Given this list of marker genes Vps72, Gfod1, Car14, Cnot8 (CCR4-NOT transcription complex, subunit 8), Atosb, Cacng2 (calcium channel, voltage-dependent, gamma subunit 2), Ap4m1, Mvk, Mttp, Oxsr1, Zfyve19, Tpm1, Nr6a1 (nuclear receptor subfamily 6, group A, member 1), Snip1, Btbd2, Mrtfa, Ikzf5, Hypk, Gm12002, Tcta, Tonsl, 1700122E12Rik, Inpp5e (inositol polyphosphate-5-phosphatase E), Sp3os (NCBI Gene Id 67686), Uckl1, Ap1g1, Plod3, Azin1, Mylk3, Hcfc1r1, Mrpl1, Rab40c, Zbtb7a, Hnrnpd, Fhod3, Habp4, Gm9955, Usp30, Plekha7, Mir2139, Fhod1, Pla2g5, Gins4, 6430573P05Rik (NCBI Gene Id 403193), Arl5b, Add3 (NCBI Gene Id 98171), Washc2, Cep152, 4933427E11Rik, Banp, Wdfy1, Sorbs2, Dnajc15, Haus8, Rcan2, Ndufa12, Prune2, Sharpin, Ctbp1, Smu1, Tacc3, Sec14l1, Baiap2l1, Prdx5, Cd36, Pcm1, Gm25630, B230369F24Rik, Spsb3, Ap3s2, Tmem120b, Ddx59, Gbe1, Aebp2, 1700086O06Rik, Dusp7, Ate1, Cox20, Uqcc1, 4933427D14Rik (NCBI Gene Id 97740), Gm4189, Mepce, Ciz1, Gstz1, Gm15612 (predicted gene 15612), Mob1b, Bloc1s1, Gm2287, Med31, Tcof1, Aldh16a1, Erh, Man1c1, Rnf31, Psmd12, Ndufb3, Rwdd1, Tnfrsf21, Zfp446, Lrrc3b, Cfap300, Polr1a, Pygo2, Kat14, Cep95, Smad3, Adal, Ttc9c, Ostm1, Gm9917, Ankrd16, Mir22, Trip12, Pgm2l1, Grk4, Samm50, Wdfy2 (WD repeat and FYVE domain containing 2), Tns3, Mrps25, Ifrd1, Prn, Tgfbr3, Pip5k1c, Tpk1, Nat10, Slc35f6, Ggct, Nmrk2, Rbsn, Gga2, Uggt1, Nhlrc3, Uck1, Hjv, Fdxacb1, Slc25a19, Gm38250, Ap1m1, Slc66a3, Mlec, Gm15523, Etfb, Casc3, Zbtb40, 4921536K21Rik, Serac1, Mybpc3, Gdi2, Esyt2, Cul2, Dbi, Pum2, Tnni3, Arid1a, Prkra, Timm10, Trib2, Phlda1, Naa40 (NCBI Gene Id 70999), Odad4, Cep41, 9430038I01Rik, Atxn7l1, Ccnl1, Ptpdc1, Gm10778, Pvr, Rhoa, Gtf2h3, Dimt1, Nop14, C9orf72, Suco, Esrrb, Tial1, Mtln, Ndufa10, A130014A01Rik, 1700007L15Rik, Idi1, Rbm27, Psma1, Inf2, Atp6v0d1, Asap1, Srsf6, Mir1191b, Frmd6, Ndufa5, Wipf2, Six5, Dhrs7, Hmcn1, Mrpl43, Dedd, Ddx42 (DEAD box helicase 42), Appl2, Zfp62, Rae1, Asb15, Alg11, Foxo6os, Pbx1, Dpy30, Rbm20, Tmem94, Hectd2os, Atn1, Ntmt1, Nexn, Fry, Rnf139, Zfp106, Jak1, Tpst2, Rap1gap2, Amotl2, Top3b, Mtmr6, Gm16793, Aamdc, Rbis, Nup54, Capzb (capping actin protein of muscle Z-line subunit beta), Ube2d3, Tmem51os1, Klhdc7a, Arl14ep, Invs, Usp31, Clptm1l, Dleu2, Dnajc16, Mrps26, Zcwpw1, Pmp22, Nceh1 (NCBI Gene Id 320024), Arhgap23, Gm12860, Odad3 (outer dynein arm docking complex subunit 3), Mindy2, Elac2, Klf13, Btrc (NCBI Gene Id 12234), Etl4, Pdhb, Mtx1 (NCBI Gene Id 17827), 3300002A11Rik, Trmt112, Rmi1, Dgkz, Atox1, Slc39a9, Rsrc1, Napepld, Atp7b, Ephx2, Xpo1, Lrrc27, Hsp90ab1, Rnf44, Fam220a, Fkbp4, Cul9, Zfp142, Gm22357, Smpd3, Pphln1-ps1, Pdp1 (pyruvate dehydrogenase phosphatase catalytic subunit 1), Foxp4, Ttc13, Taok3, Gnao1, Myo6 (myosin VI), Mtfr1l, Rxylt1 (ribitol xylosyltransferase 1), Firrm, Cenpc1, Cdkl3 (NCBI Gene Id 213084), Kmt2a, Ppp1r13b, Svil, C630043F03Rik, Mars1, Tead1, Bahcc1, Sertad2, Gmpr2, Tbc1d9b, Pank3, Mcee, Gstm1, Smyd1, A430035B10Rik, Ssbp2 (single-stranded DNA binding protein 2), Speg, Tcea1, Dusp18, Tent4b, 5430400D12Rik, Ankrd9, Grn, Mphosph10, Wars1, Kmt5a, Tnfaip8, Efhc1, Pabpc4, Raf1, Mir191, Mcfd2, Gucd1, Apobec2, Nup58, Phf1 (NCBI Gene Id 52012), Nedd8, Ift25, 4930583K01Rik, Lrrc10, Klhl12, Schip1, Ndufv3 (NCBI Gene Id 78330), Bltp2, Mbtd1, Plk3, Cbr2 (NCBI Gene Id 12409), Selenok, Arhgef19, Mir7238, Oplah, Tab1, Fyn, Gm9968, Hspb6, Setd1a (SET domain containing 1A), Zcchc2, Rptor, Ppm1h, Psmd13, Mir17hg, A730020M07Rik, Ezh2, Myom2, Znhit3, Ifngr1, Ubap2, Gm12092, P2rx4, Rtl5, Stard3, Pinlyp, Cipc, Popdc2, Ralgapb, Nuak1, Tsc1, Acrv1 (NCBI Gene Id 11451), Cab39l, Lyset, Shroom3, Tst, Tmem65, Ndufc2, Otof, Ears2, Erc1, Set, Ralgps2, Cep290, Dip2c (NCBI Gene Id 72929), Napa, Abcg2, Kcnk3, Nub1, Trmt10a, Prrg2, 6230400D17Rik, Hhatl, Nolc1, Orai1, Eml4, Mertk, Pdcl3, Unc50, Hycc2, Mrpl2, Adprhl1, Mir3091 (NCBI Gene Id 100526556), Cops4, Atg9a, Tmem171, Trim63, Wdr4, Cox8b, Phf19, Hnrnpk, Vhl, Gm26224, Polr1f, Chchd1, Prkag1, Ltbp4, Mm2pr, Gm23119, Zfp384, Lactb, Lmbrd1, Fzd2, Stat5a, Rrad, Fbxl19, Gm4419, Acacb, Arhgef12, Mybpc2, Mrpl47, Gpsm1, Idh1, Ddx49, Tnik, Rnf123, Fam131a, Thoc6, Kdm2a, Robo2, Ptbp1, 4930405A21Rik, Rsf1, Neo1 (NCBI Gene Id 78386), Polr3e, Psme2 (NCBI Gene Id 19188), 4833445I07Rik, Opn1sw, AW209491, Zfp975, Pik3cb, Fam136a, Vps13d, Hspb2, P4ha2, Eci1 (enoyl-Coenzyme A delta isomerase 1), Iffo1, Rpl13a, Prmt2, Hmgb1, Zfp113, Plcxd2, 4933440J02Rik (RIKEN cDNA 4933440J02 gene), Rbm38 (NCBI Gene Id 56190), F730043M19Rik, Fmc1, Pnrc1, Adck5, Prkar1b, Pcid2, Ube2g1, Edrf1, Stoml2, Ankrd50, Fam32a, Mrps36, Vdac2, Lmod2, Pdha1, Vac14, Uri1, Sar1a, Rdh5, Scube2, Clcc1, Ogdh, Nubp2, C630004L07Rik, Nkiras1, Zbtb37, Rcor2, Slc35e2, Nubpl (nucleotide binding protein-like), Mafa (MAF bZIP transcription factor A), Tmco3, Nol11, Ino80, Mir8098, Esco2, Ubr2, Cep85, Kdm4b, Htra2, Odr4, Fam53a, Mexis, Stc2, Slc39a14, Tlcd1, Klc4, Sirt3, Gm11511, Atp6ap1, Cfap68, Tmem170b, Exo5, Syne1, Noct, Tpr, Abhd11, Cdca3, Abtb1, Fn3krp, Afg1l, Mb, Pum3, Prdx3, Mob2, Lonp1, Rapgef2, Adora1, Mtx3, Cgrrf1, Pmm1, Ube2i, Ago1, Synpo, Strit1, Fbh1, Jade1, Rps21, Pet117, Pet100, N6amt1, Trap1, Tecrl, Rbm14, Smg1, Ppp3ca, Cul4a, Mcmbp, Mettl18 (methyltransferase like 18), Bach2, Acadsb, Tbl2, Lsm11, Txndc9, Itgb3bp, Parm1, Atp5mc3, Proser3, Abra, A730061H03Rik, Rassf1, Mgat4b, Ube2e2, Lcn5, Snord3a, Calr (NCBI Gene Id 12317), Coro6, P3h1 (prolyl 3-hydroxylase 1), Arv1, Etfa, Glcci1, Acaa2, Phactr4, Rangap1, Wdr19, Gm25794, Rab3gap1, BC005624, Txndc11, Mir7117, 6430571L13Rik, Tbc1d14, Gpn1, Qki, Ttc39b (NCBI Gene Id 69863), Fubp1, Prkag3, Pfkfb4, Irgq, Tomm6, Serinc1, Sardh, Ubfd1, Trmt10b, Txndc17, Samd1, Dner, Fbxw7, Emc2, Fxyd1, Rmc1, Tor1aip1, Zfp458, Cdk2ap1, Shld1, Tmem129, Nxn, Gas5 (growth arrest specific 5), Ahcyl2, Ccdc59, Ptcd1, Tbl1xr1, Bbs10, Hmg20a, Hspb7, Alpk2, Gm22394, Xab2, Paxx, Agpat3 (1-acylglycerol-3-phosphate O-acyltransferase 3), Hspb8, Ccdc47, Pex1, Orm3, Usp20, Ube2b, Hdac5, Tmtc3, Pcsk5, Mrpl49, Fbxo36, Utp18, Serbp1, 1810021B22Rik, Gata4, Adamts3, Mef2c, Lipt1, Gatd1, Limch1 (NCBI Gene Id 77569), Lgr6, Apbb1, Prkca, Erp44, Nectin2, Zfp777, Dhx36, Gemin6-ps, Gm9903, Irx3, Tnnt2, Bbof1, Maf1, Rfx1, Oxnad1, Slc25a39, Dusp1, Osbpl8, Phka1, Elmod3, Dhcr7, Mad1l1, Fitm2, Fbxo46 (NCBI Gene Id 243867), Bod1l, Pjvk, Alkbh5, Trp53rkb, Gm22489, Ccdc150, Mesd, Igfbp4, Hs6st1 (NCBI Gene Id 50785), Atg2a, Eapp, Chd3, Pdlim5, Gm15270, Katnip, Snd1, Prdm4, Api5, Pih1d1, Txn1 (NCBI Gene Id 22166), Ciao2b, Gfus, Gm14488, 6030469F06Rik, Sned1, Myom3, Hdgf, Katnb1, Ankrd10, Retsat, Lamc1, Dolk (dolichol kinase), Dnajc11, BB218582, Ccdc85c, Ints4, Rex1bd, Wdr25, Ndufaf3, Atp5mf (ATP synthase membrane subunit f), Cul5, Klhl26, Cbr4, Tmem266, Cpsf4, Clp1, Ggps1, Ptgs1, Aup1, Slc50a1, Rnf13, Klf4, Ppp2r5a (protein phosphatase 2, regulatory subunit B', alpha), Nsun6, Meak7, Dnali1, Igfals (NCBI Gene Id 16005), Tbc1d2, Pcgf5, Gm4219, Fosl2, Hnrnpl, Rbpj, Unc5b, Kctd3, Ptcd3, Nucks1, Arhgap35, Kyat3, Hibadh, Rreb1, Fhl2, Dcakd, Sh2b1, Dele1, Golph3, Ctsb, Gm28047, 4833417C18Rik, A530016L24Rik, Ctsd, Caprin1 (NCBI Gene Id 99144), Magi3, Rnf8, Vamp4, Ro60, Tle1, Prnp, Wbp4, Apba1, Trabd, Wdr5b, Gm24355, Hes6, Ndufs6, Ubtd2, Acaa1a, Tars3, Scaf8, Ehd1, Gm10069, Nosip, Ncor2, Otud1, Asph, Ankrd39, Atf7 (activating transcription factor 7), Cttn, Plec, Gtf3c6, Arfgap2, Trp53bp1, 1700123M08Rik, Ankzf1 (ankyrin repeat and zinc finger domain containing 1), Scgb1c1, Cish, Cope, Trim54, Mmab, Gm10373, Irx3os, Ptges3l, Ndufa9, Gramd4, Wipi1, 3110009E18Rik, Ccny, Tgm2, Gm15627, Sh3gl1, Rnf24, Plk2, Wdr1, Rbm25, Gm7160, Obsl1, Stam, Ctps1, Gm27252, Lmcd1, Ikzf2, Tmem183a, Tmem64, Ahcyl1, Rapsn, Plbd1, Dcp1a, Sgo2a, Pex6, Zbtb20, Ces1d, Akt2, Kdm4a, Gtf2h5, Xrcc1, Sugp2, 4930488L21Rik, Efcab2, Dlgap4, Nr3c1, Ccdc171, Lrrc28, Ctu1, Pgs1, Mir7653, Ywhaq, Fxr2, Mphosph6, Mhrt (NCBI Gene Id 791403), Ism1, Peak1, Dnaja4, Ccdc71, Blcap, Zfp128, Urgcp, Sptb, St6galnac6, B3gntl1, Siah1a, 5830454E08Rik, Mir5625, Cuta, Ddx5, Camk2a, Supt5, Pold3, Ankrd23, Prkcsh, Rilp, Twf2, Gm10101, Gm12409, Cbx8 (NCBI Gene Id 30951), Epc1, Ppp1r12b, Fau, Pigg, Rundc1, Rpn2, Vapb, Mtrfr, Il11ra1, Setdb2, Mettl25, Map4, Armh3, Nck1, Mir9769, Cdk4, Galt, Rbm48, Uspl1, Zdhhc7, Sigmar1, Thg1l, Capn5, Snx16, 2210408F21Rik, Twnk, Ppm1a, Fsd2, Lrrc52, Gm16163, Fbxl20, Specc1, Nup188, Nt5e (5' nucleotidase, ecto), Aacs (acetoacetyl-CoA synthetase), Gpr155 (NCBI Gene Id 99360), 4930473A02Rik, Tfeb, Lipe, Phip, Znhit1, Afg3l2, 1110002L01Rik, Thbs3, Polr3a, Cep97, Ell, Dhx35 (NCBI Gene Id 71715), Snupn, 4930483J18Rik, Ndufb5, Ank, Scaf11, Eif2b1, Cacng3, Ift74, Pdia5, Acsl1, Vegfb, Dnajb4, Frs3, 9330111N05Rik, Nup155, Atg101, 2310016G11Rik, Tns1, Mov10l1, Irf2bp2, Amigo3, Actb, Cdin1, Tfcp2l1, Gm32391, Rab11fip2, Ppp6c, Zng1, 1700082M22Rik, Entpd5, Gsk3a, Asb2, Bcs1l, Plaat3, Clptm1, Tubgcp5, Sh3bp5, Smg6, Por, Radil, Nt5m, Maz, Nktr, Castor2, Ak1, Arhgap21, Myl3, Gnb2, Rpl3l, Arf6, Eif5b, Slc43a2, Nr4a3, Zfp367, Ech1, Nectin3, Gm2a, Sertad1, Mir1893, Usp5, Mtmr3, Gtpbp1, Bfar, Slc39a13, Arpc5l, Vpreb1a, Got1, BC004004, Ampd3, Dcaf11, Lrrc75b (NCBI Gene Id 216109), Adss1, Zfp207, Hyal2, Mxd4, Myo9b, Gm26787, Thrap3, Epo, AA474408, Metap2, Dazap1, Atp8a1, Dnajc17, Slc9a5, Pam, Actn2, Myocd, Zfp710, Abca2, Arid4b, Cox5b, Nkain1, Mpst (mercaptopyruvate sulfurtransferase), Anapc16, Gnptg, Adprs, Gm5432, Septin9, D230022J07Rik, Snrpd3, Cdk20, Czib, Pdk4, Plxnd1, Ipo11, Ice1, Ldha, Fem1b, Rps27l, Sesn3, 2310057M21Rik, Stt3a (NCBI Gene Id 16430), Lrba, Rpl5 (ribosomal protein L5), Gm21992, 2410021H03Rik, Hes1, Cep131 (NCBI Gene Id 12009), Atg16l1, Emsy, Cd99l2, Ube2uos, Srrm2, Bsg, Mrpl44, Rplp0, Mbip, Slc25a5, Adissp, Poc5, Phyhd1, Scarna17, Mrps18a, Asxl2, Clu, Cacnb2, Gm28043, Flywch1, Plpbp, Tgfbr1, Ric8b, Zfp628, Spata2, Gm14963, Orm2, Commd5, Ncs1, Dbp, Gamt, Prdm9 (PR domain containing 9), Pxn, Slc38a3, Il15ra, Bcorl1, Zfp148, Mrnip, Rpl15, 4930539J05Rik, Stn1, Hdhd3, Xpo6, Moap1, Dph3, Apba3, Ube2n, Dgkd, Aftph, Trpm7, Mcm7, Garem1, Pias4, Kcnj2, Bmpr1b, Lrrc42, Hnrnpa0 (heterogeneous nuclear ribonucleoprotein A0), Birc6, Scg2, Bhlhe40, Gm5444, Plin4, Slc27a1, Tmed2, Des, Bicd2, Coa5, Lamb1, Ddit4, Dmrt1i, Fchsd2, Prickle3, Scaf1, Proser1, Dnaaf5, Mir99ahg, Ntn1, Ldhb, Pitpna, Frmd4a, Mapk1, Ppil1, Tcf4, Tmem11, B230206L02Rik, Gatad2a, Cox6a2, Nudt9, Uchl5, Gapdh, Klhdc8b, Rorb, AU022252, Rabgap1, Nr1d1, Tsr3, Slc25a36, Gm10097, Pop7, Tcea3, Ndufab1, Wiz, Nutf2, Ddit3, Pkm, Zfp36l2, here is a description of the gene set: from publication Yevshin I, Sharipov R, Kolmykov S, Kondrakhin Y, Kolpakov F (PMID 30445619) Genes containing one or more binding sites for (Zfp449) in their promoter regions (TSS -1000,+100 bp) as identified by GTRD version 20.06 ChIP-seq harmonization. species: Mus musculus Mouse Gene Set: ZFP449_TARGET_GENES